Given this list of marker genes AOPEP, ALDH1A3, IRF5, MAP1LC3B, OPTN, AHR, FILIP1L, CDKN2A, HTATIP2, CREG1, SPARC, HPS5, MAP2K3, CLTB, TSPYL5, TP53, CCN2, CYP1B1, NDN, IGFBP7, IFI16, CDKN1A, IRF7, IGFBP6, TGFB1I1, IGFBP4, IGFBP5 (NCBI Gene Id 3488), IGFBP3, RB1, HTRA1, HSPA2, CXCL14 (C-X-C motif chemokine ligand 14), SERPINE1, here is a description of the gene set: studied in species Homo sapiens Human Gene Set: FRIDMAN_IMMORTALIZATION_DN Bypassing cellular senescence and becoming immortal is a prerequisite step in the tumorigenic transformation of a cell. It has long been known that loss of a key tumor suppressor gene, such as p53, is necessary, but not sufficient, for spontaneous cellular immortalization. Therefore, there must be additional mutations and/or epigenetic alterations required for immortalization to occur. Early work on these processes included somatic cell genetic studies to estimate the number of senescence genes, and microcell-mediated transfer of chromosomes into immortalized cells to identify putative senescence-inducing genetic loci. These principal studies laid the foundation for the field of senescence/immortalization, but were labor intensive and the results were somewhat limited. The advent of gene expression profiling and bioinformatics analysis greatly facilitated the identification of genes and pathways that regulate cellular senescence/immortalization. In this review, we present the findings of several gene expression profiling studies and supporting functional data, where available. We identified universal genes regulating senescence/immortalization and found that the key regulator genes represented six pathways: the cell cycle pRB/p53, cytoskeletal, interferon-related, insulin growth factor-related, MAP kinase and oxidative stress pathway. The identification of the genes and pathways regulating senescence/immortalization could provide novel molecular targets for the treatment and/or prevention of cancer. Genes down-regulated in immortalized cell lines. from publication Fridman AL, Tainsky MA (PMID 18711403)